The following is a description of a gene set: species: Mus musculus A protein-DNA complex assembled at eukaryotic DNA replication origins immediately prior to the initiation of DNA replication. The preinitiation complex is formed by the assembly of additional proteins onto an existing prereplicative complex. In budding yeast, the additional proteins might include Cdc45p, Sld2p, Sld3p, Dpb11p, DNA polymerases, and others; in fission yeast the GINS complex is present. Mouse Gene Set: GOCC_DNA_REPLICATION_PREINITIATION_COMPLEX, and this is the list of marker genes: Slc5a8, Mcm7, Mcm6, Mcm3, Gins2, Orc3, Gins4 (GINS complex subunit 4), Gins3, Gins1, Cdc45, Mcm4, Mcm5, Mcm2